Given this list of marker genes Sar1b, Sar1a, Sec16a, Mapk15, Preb, here is a description of the gene set: Mouse Gene Set: GOBP_REGULATION_OF_COPII_VESICLE_COATING studied in species Mus musculus Any process that modulates the rate, frequency, or extent of the addition of COPII proteins and adaptor proteins to ER membranes during the formation of transport vesicles, forming a vesicle coat.